The following is a description of a gene set: Human Gene Set: GOBP_REGULATION_OF_INTRINSIC_APOPTOTIC_SIGNALING_PATHWAY_IN_RESPONSE_TO_OSMOTIC_STRESS species: Homo sapiens Any process that modulates the frequency, rate or extent of intrinsic apoptotic signaling pathway in response to osmotic stress., and this is the list of marker genes: YBX3, PTGS2, EPO, TIFAB, BDKRB2, ARHGEF2, BAD, USP15